The following is a description of a gene set: Human Gene Set: REACTOME_REGULATION_OF_FOXO_TRANSCRIPTIONAL_ACTIVITY_BY_ACETYLATION Regulation of FOXO transcriptional activity by acetylation studied in species Homo sapiens, and this is the list of marker genes: TXN, KAT2B, SIRT1, FOXO4, FOXO3, SIRT3, CREBBP (NCBI Gene Id 1387), EP300 (E1A binding protein p300), TXNIP, FOXO1